The following is a description of a gene set: species: Mus musculus Mouse Gene Set: GOBP_RESPONSE_TO_LIPOPROTEIN_PARTICLE Any process that results in a change in state or activity of a cell or an organism (in terms of movement, secretion, enzyme production, gene expression, etc.) as a result of a lipoprotein particle stimulus., and this is the list of marker genes: Tlr4, Cd9, Ces1e, Fcer1g, Smpd3, Apoe, Ces1h, Tgfb1, Myd88, Ces1a, Socs5, Itgb1, Casr, Cdh13, Ces1f, Ces1g, Cd36, Pparg, Ces1c, Mia3, Ces1b, Ticam1, Akt1, Tlr6, Cd68, Ldlr, Hmgcs1, Npc1, Mylip, Cd81, Adtrp (NCBI Gene Id 77346), Syk, Mexis, Ces1d, Lpl, App, Itgb2, Mir124a-1hg, Srebf2, Trem2